The following is a description of a gene set: Mouse Gene Set: GOBP_POSITIVE_REGULATION_OF_CENTRIOLE_ELONGATION Any process that activates or increases the frequency, rate or extent of centriole elongation. species: Mus musculus, and this is the list of marker genes: Cep295, Cenpj, Vps4b, Ppp1r35, Cep120 (centrosomal protein 120), Poc1b, Ccdc15